The following is a description of a gene set: The acrosomal membrane region that underlies the acrosomal vesicle and is located toward the sperm nucleus. This region is responsible for molecular interactions allowing the sperm to penetrate the zona pellucida and fuses with the egg plasma membrane. Human Gene Set: GOCC_INNER_ACROSOMAL_MEMBRANE studied in species Homo sapiens, and this is the list of marker genes: SPACA4, EQTN, CD46, TMEM190, IZUMO3, SPACA1